The following is a description of a gene set: species: Homo sapiens part of: Downstream signaling of activated FGFR1 Reactome Pathway: Phospholipase C-mediated cascade: FGFR1 Phospholipase C-gamma (PLC-gamma) is a substrate of the fibroblast growth factor receptor (FGFR) and other receptors with tyrosine kinase activity. It is known that the src homology region 2 (SH2 domain) of PLC-gamma and of other signaling molecules (such as GTPase-activating protein and phosphatidylinositol 3-kinase-associated p85) direct their binding toward autophosphorylated tyrosine residues of the FGFR. Recruitment of PLC-gamma results in its phosphorylation and activation by the receptor. Activated PLC-gamma hydrolyzes phosphatidyl inositol P2 to form the second messengers diacylglycerol (DAG) and InsP3, which stimulate calcium release and activation of calcium/calmodulin dependent kinases.<br>, and this is the list of marker genes: FGF22, FGF10, FGF20, PLCG1, FGF8, KL, FGF17, FGFR1, FGF6, FGF23, FGF3, FGF1 (NCBI Gene Id 29961), FGF5, FGF4, FGF2, FGF9